The following is a description of a gene set: Human Gene Set: HP_GOWERS_SIGN Gowers sign A phenomenon whereby patients are not able to stand up without the use of the hands owing to weakness of the proximal muscles of the lower limbs. studied in species Homo sapiens, and this is the list of marker genes: FILIP1, CHKB, VMA21, PHKG1, STAC3 (NCBI Gene Id 246329), ASAH1, GFPT1, SECISBP2 (SECIS binding protein 2), RNU12, TAFAZZIN, POMK, RYR1, GMPPB, SGCD (NCBI Gene Id 6444), DOK7, COL12A1, SNUPN, ORAI1 (ORAI calcium release-activated calcium modulator 1), TK2, ATP6V1E1, RAPSN, CHRNE, DMD, FDX2, SPEG, POMT1 (protein O-mannosyltransferase 1), PNPLA8 (NCBI Gene Id 50640), MICU1, SPTLC1, TTN, CHRNA1, TNNT1, PYROXD1, CFL2, DAG1, PNPLA2 (NCBI Gene Id 57104), POMGNT1, TPM3, COL6A1, NEFL, GATM, COL6A3, TRAPPC11, TRPV4, ITPR1, SGCG, DNAJB6, TRIM32, RYR3, DNA2, COQ7, DPAGT1, BICD2, DPM3, SYNE1, LMNA, BIN1, FKTN, HACD1, INPP5K, PLEC, SGCA, ACTA1, SCN4A, CAPRIN1, ITGA7, LAMA2, PHKA1, MYPN, TPM2, UNC45B, PUS1, CAV3, POMGNT2, ALG14 (ALG14 UDP-N-acetylglucosaminyltransferase subunit), VAPB, ALG2, ACBD5, MSTO1 (misato mitochondrial distribution and morphology regulator 1), COL6A2, SELENON, MUSK, SGCB